The following is a description of a gene set: species: Homo sapiens The series of molecular signals initiated by a SLIT protein binding to a Roundabout (ROBO) family receptor on the surface of a target cell, and ending with the regulation of a downstream cellular process, e.g. transcription. Human Gene Set: GOBP_ROUNDABOUT_SIGNALING_PATHWAY, and this is the list of marker genes: SLIT3, SLIT2, MYO9B, RHOA, ROBO1